Given this list of marker genes Cyp4a32, Cyp4f15, Cyp2u1, Cyp4f40, Cyp4a10, Cyp4a29, Cyp4v3, Cyp4f14, Cyp4a12a, Cyp4a31, Cyp4a12b, Cyp4f13, Cyp4f18, Cyp4a30b, Cyp4a14, Cyp1a1, here is a description of the gene set: Mouse Gene Set: GOMF_FATTY_ACID_OMEGA_HYDROXYLASE_ACTIVITY Catalysis of the reaction: an omega-methyl fatty acid + O2 + reduced = an omega-hydroxy fatty acid + H+ + H2O + oxidized. studied in species Mus musculus